The following is a description of a gene set: species: Homo sapiens part of: Signaling by NOTCH3 Reactome Pathway: NOTCH3 Activation and Transmission of Signal to the Nucleus NOTCH3 receptor can be activated by DLL/JAG ligands DLL1, JAG1, and JAG2, as well as DLL4. Ligand binding induces a conformational change in NOTCH3, which exposes the S2 site in the extracellular region of NOTCH3. The S2 site is cleaved by ADAM10 metalloprotease, generating the membrane anchored NOTCH3 fragment NEXT3. The NEXT3 fragment of NOTCH3 is further cleaved at the S3 site by the gamma secretase complex, releasing the intracellular domain NICD3 into the cytosol. Besides DLL/JAG ligands, NOTCH3 signaling can also be activated by binding of NOTCH3 to YBX1 (YB 1). NICD3 traffics to the nucleus where it acts as a transcription factor. WWP2, an E3 ubiquitin ligase, negatively regulates NOTCH3 signaling by ubiquitinating NEXT3 and NICD3 in the cytosol and targeting them for lysosome-mediated degradation. NOTCH3 signaling is also negatively regulated by binding to TACC3 and by EGFR-mediated phosphorylation., and this is the list of marker genes: WWP2, EGFR (NCBI Gene Id 1956), NCSTN, UBB, PSEN1 (presenilin 1), MIB2, DLL1, EGF, MIB1, RPS27A, NOTCH3, NEURL1B, UBC, ADAM10, YBX1, JAG2, UBA52, JAG1, APH1B, APH1A (aph-1 homolog A, gamma-secretase subunit), DLL4, TACC3, PSENEN, PSEN2, NEURL1